The following is a description of a gene set: species: Homo sapiens Any process that results in a change in state or activity of a cell (in terms of movement, secretion, enzyme production, gene expression, etc.) as a result of a progesterone stimulus. Human Gene Set: GOBP_CELLULAR_RESPONSE_TO_PROGESTERONE_STIMULUS, and this is the list of marker genes: ACOD1, SRC (NCBI Gene Id 6714), TRERF1, SOX10, VPS54